The following is a description of a gene set: Mouse Gene Set: ZHANG_ADIPOGENESIS_BY_BMP7 studied in species Mus musculus Genes up-regulated in C3H10T1/2 cells (mesenchyme multipotent cells) upon their differentiation to brown adipocytes in response to BMP7. from publication Zhang H, Schulz TJ, Espinoza DO, Huang TL, Emanuelli B, Kristiansen K, Tseng YH (PMID 20584981) Both insulin and bone morphogenetic protein (BMP) signaling systems are important for adipocyte differentiation. Analysis of gene expression in BMP7-treated fibroblasts revealed a coordinated change in insulin signaling components by BMP7. To further investigate the cross talk between insulin and BMP signaling systems in brown adipogenesis, we examined the effect of BMP7 in insulin receptor substrate 1 (IRS-1)-deficient brown preadipocytes, which exhibit a severe defect in differentiation. Treatment of these cells with BMP7 for 3 days prior to adipogenic induction restored differentiation and expression of brown adipogenic markers. The high level of adipogenic inhibitor preadipocyte factor 1 (Pref-1) in IRS-1-null cells was markedly reduced by 3 days of BMP7 treatment, and analysis of the 1.3-kb pref-1 promoter revealed 9 putative Smad binding elements (SBEs), suggesting that BMP7 could directly suppress Pref-1 expression, thereby allowing the initiation of the adipogenic program. Using a series of sequential deletion mutants of the pref-1 promoter linked to the luciferase gene and chromatin immunoprecipitation, we demonstrate that the promoter-proximal SBE (-192/-184) was critical in mediating BMP7's suppressive effect on pref-1 transcription. Together, these data suggest cross talk between the insulin and BMP signaling systems by which BMP7 can rescue brown adipogenesis in cells with insulin resistance., and this is the list of marker genes: Map3k5, Sgk1, Grb2, Grb10, Pik3c2a, Myo1c, Mapk3, Sh2b2, Pik3r1, Irs1, Hras, Grb14, Akt1, Akt2